Given this list of marker genes ARHGAP45, ITGB7, GNMT, NETO2, RAB5C, DGKQ, PRXL2B, EIF3L, PPP1R12C, UBE4A, BNIP2, GALNT4, WSB2, NUP155, C1orf74, CLN3, TIAM2, RACGAP1, RTRAF, RPRD2, VPS25, VIRMA, TPM3, ZBTB48, C1orf52, STRADB, PEDS1, FOXD4L1, RIPK1 (receptor interacting serine/threonine kinase 1), CCR1, ANLN, NRBF2, KIF1C, DDX31, TMEM120A, ACRBP, DNAJA1, NCBP2, KCNIP3, CTPS1, HLX, TNIK, MED11, IFIT1, PBXIP1, YPEL3, DENND2B, FABP5, HCLS1, RPS11, SERTAD4, SELENOS, LTO1, RABIF, DIAPH2, CNOT11, RPL13 (NCBI Gene Id 6137), NMT2, SPAG16, PSD4, MED10, ZNF652, PDCD1LG2, CCNB1IP1, KCNC1, PPP2R5E, EED, RNPEPL1, NHERF4, COG3, BICD2, MARS2, APOBR, TAF8, AGBL4, DBNL, DDX11, RPL39, FBXO32, NCALD, IFI30 (IFI30 lysosomal thiol reductase), DNAAF2, HEY2, FANCD2, PIR, PIGF, TMOD4, SETD4, ATP6V0B, TXNIP, FHIP2A, POLR1E, ALDH18A1, TUBB2B, MRS2, SCFD2, INHBA, FANCB, NLRC3, HSD17B7, COX11, THAP7, PTPRCAP, CETN1, GLRX3, ZBTB32, MARVELD2, FXR1, GOLGA4, SLC11A1, RNF19A, TRIM41, AMBRA1, SETD2, PIK3CG, EMC3, PIGH, FBLN2, FBRSL1, DYNLRB1, TIMM17B, TSR1, RPS8, CDK14, MAN2A1, CARD19, CHST12, MIA2, COMMD1, TTC39C, DNAJC3, RUFY3, TNFAIP1, FANCM, DZANK1 (double zinc ribbon and ankyrin repeat domains 1), WDR26, UBR2, RNF128, ERRFI1, GMPPB, TBPL1, ARHGAP25 (Rho GTPase activating protein 25), BNC2, MYCBP, WWP2 (WW domain containing E3 ubiquitin protein ligase 2), PKD2L2, RFNG, RBBP7, PSMB4, CSF2, MED17, ATP6V1B2, SLC30A9, POLR3F, ACBD4, GGNBP2, USP40, LIMK2, ULK3, DHODH, SLC66A3, METTL21A, SEC63, IFNGR1, SLC52A2, SCML4, KBTBD3, AIP, POGLUT3, RAP2A, COG7, CREBBP, NUP133, CAMLG, ZNF800, UTP15, ZNF628, DHRS3, STMP1, HSPB1, EMC1, INCENP, FYTTD1, MCF2L, PPIP5K1, DEPDC1B, LIN9, CX3CR1, DBI, DCTN4, QTRT2, OTUD5, SIRT1, TMEM258, SUV39H1, SIK2, PHF1, PSMA2, FAM219B, SREBF1, here is a description of the gene set: from publication Kim TD, Terwey TH, Zakrzewski JL, Suh D, Kochman AA, Chen ME, King CG, Borsotti C, Grubin J, Smith OM, Heller G, Liu C, Murphy GF, Alpdogan O, van den Brink MR (PMID 18178870) Human Gene Set: GSE5503_LIVER_DC_VS_SPLEEN_DC_ACTIVATED_ALLOGENIC_TCELL_DN species: Homo sapiens Genes down-regulated in allogeneic T cells after stimulation with dendritic cells from: liver versus spleen. Transcriptional response of murine allogeneic T cells (B10.BR) after stimulation with different organ-derived (spleen, liver, peripheral and mesenteric lymph nodes) dendritic cells (C57BL/6) in vitro